The following is a description of a gene set: This event has been computationally inferred from an event that has been demonstrated in another species.<p>The inference is based on the homology mapping from PANTHER. Briefly, reactions for which all involved PhysicalEntities (in input, output and catalyst) have a mapped orthologue/paralogue (for complexes at least 75% of components must have a mapping) are inferred to the other species. electronically inferred by orthology from the curated human pathway studied in species Mus musculus part of: RAF/MAP kinase cascade Reactome Pathway: MAP2K and MAPK activation, and this is the list of marker genes: Itga2b, Cnksr1, Lamtor2, Apbb1ip, Cnksr2, Tln1, Hras, Pebp1, Arrb2, Map2k1, Ksr2, Map2k2, Fgg, Mapk3, Csk, Wdr83